The following is a description of a gene set: species: Mus musculus Any process that modulates the frequency, rate or extent of motor neuron apoptotic process. Mouse Gene Set: GOBP_REGULATION_OF_MOTOR_NEURON_APOPTOTIC_PROCESS, and this is the list of marker genes: Bag1, Rock1, Erbb3, Clcf1, Bax, Rapsn, Musk, Map2k7, Mir124a-1, Map3k12, Agrn, Rhoa, Crlf1, Cntfr, Kcnb1, Vps54, Zpr1, Nefl, Bcl2, Map2k4